Given this list of marker genes CAMKMT, EEF1AKMT2, EEF2, METTL22, EEF1A1 (NCBI Gene Id 96648), HSPA8, VCP (NCBI Gene Id 94731), METTL21A, KIN, CALM1, ETFBKMT, RPS2, EEF2KMT, ETFB, PRMT3, VCPKMT, EEF1AKMT1, here is a description of the gene set: Methylation of lysine (Lys) and arginine (Arg) residues on non-histone proteins is a prevalent post-translational modification and important regulator of cellular signal transduction pathways including MAPK, WNT, BMP, Hippo and JAK–STAT. Crosstalk between methylation and other types of post-translational modifications and between histone and non-histone protein methylation is frequent, affecting cellular functions such as chromatin remodelling, gene transcription, protein synthesis, signal transduction and DNA repair (Biggar & Li 2015). part of: Post-translational protein modification studied in species Homo sapiens Reactome Pathway: Protein methylation